Given this list of marker genes DHRS3, PPARG, ACTN4, ZNF536, RXRB, CYP26A1, NR2C1, TGIF1 (NCBI Gene Id 91941), SNW1, RARA (retinoic acid receptor alpha), PML, CNOT1, RXRG, CYP26C1, GREB1L, THRA, SP100, THRB, RXRA, NR1H2, TBX1, RARB, KLF2, CYP26B1, ASXL1, CALR, ESRRG, NCOA3, EZH2, AKR1C3, CRKL, RARG, VDR, PRAME, ALDH1A2, TRIM16, PTF1A, CTBP2 (NCBI Gene Id 87435), here is a description of the gene set: A nuclear receptor-mediated signaling pathway initiated by a retinoic acid binding to an intracellular receptor of the nuclear receptor protein family, and ending with regulation of a downstream cellular process, e.g. transcription. species: Homo sapiens Human Gene Set: GOBP_RETINOIC_ACID_RECEPTOR_SIGNALING_PATHWAY